The following is a description of a gene set: from publication Zaslavsky E, Hershberg U, Seto J, Pham AM, Marquez S, Duke JL, Wetmur JG, Tenoever BR, Sealfon SC, Kleinstein SH (PMID 20164420) The dendritic cell (DC) is a master regulator of immune responses. Pathogenic viruses subvert normal immune function in DCs through the expression of immune antagonists. Understanding how these antagonists interact with the host immune system requires knowledge of the underlying genetic regulatory network that operates during an uninhibited antiviral response. In order to isolate and identify this network, we studied DCs infected with Newcastle Disease Virus (NDV), which is able to stimulate innate immunity and DC maturation through activation of RIG-I signaling, but lacks the ability to evade the human interferon response. To analyze this experimental model, we developed a new approach integrating genome-wide expression kinetics and time-dependent promoter analysis. We found that the genetic program underlying the antiviral cell state transition during the first 18-hours post-infection could be explained by a single regulatory network. Gene expression changes were driven by a step-wise multi-factor cascading control mechanism, where the specific transcription factors controlling expression changed over time. Within this network, most individual genes are regulated by multiple factors, indicating robustness against virus-encoded immune evasion genes. In addition to effectively recapitulating current biological knowledge, we predicted, and validated experimentally, antiviral roles for several novel transcription factors. More generally, our results show how a genetic program can be temporally controlled through a single regulatory network to achieve the large-scale genetic reprogramming characteristic of cell state transitions. Human Gene Set: GSE18791_UNSTIM_VS_NEWCATSLE_VIRUS_DC_1H_UP species: Homo sapiens Genes up-regulated in comparison of control conventional dendritic cells (cDC) at 1 h versus cDCs infected with Newcastle disease virus (NDV) at 1 h., and this is the list of marker genes: SSTR1, ADAM7, SEMA3F, CRLF1, SDCBP2-AS1, BTBD2, MTURN, TYMSOS, PRL, NPVF, ADPRHL1, SCN4B, SALL3, LIF, SMYD5, BEST2, MAP3K10, JPH1, ABCC12, STPG1, EFNB3, HAGLR, NCAM1, PTPRS (NCBI Gene Id 5802), TMEM38A, PCDH19, DUOXA2, PADI4, ANTXR1, PTTG2, MYL11, B3GALT5-AS1, ACTR3BP2, SERTAD1, TCN1, MAST4, CNTD1, KLK12, KCNJ2-AS1, WNT8B, NPSR1-AS1, TLCD4, LSAMP, PAX7, ATP6V1B1, NUDT9P1, GRK7 (G protein-coupled receptor kinase 7), ENSG00000224090, TIMD4, PTPRF, PARD3, LMX1A, TEX101, FGF12, TAS2R5, ANKRD33, DPP4, SNAP25, ODAD2, LY6D, ASB4, BRS3, LINC00471, CHTF18, STAG3L1, GLRA3, WFDC12, H2BC13, UTS2, TMEM88, PIEZO2, MYLK2, CCNT1, ESRP2, ATP4A, PPY2P, TRIM67-AS1, TEX19 (NCBI Gene Id 400629), KCND3, CCDC120, PTMS, NOXA1, IQCC, PNMA2, TEDDM1, CTSE, CELA1, SLC35D3, TNFRSF8, DYRK1B, CFAP74, ARMC2, GALNT17, ANKS4B, IDO2, RAPGEF4-AS1, TNFRSF19, LINC02223, INO80B, PLA2G2A, CYP3A7, PDX1 (pancreatic and duodenal homeobox 1), ARHGAP42, NKX1-1, TF, CASTOR3P, OR1A2, TTC9B, GAL3ST3, CDH4, HNF1B, NPPA, SMIM6, HOXA11-AS, AKR1B10, ANO7, CYP2C8, SALL4, DMD, LMNTD2-AS1, KIF5A, OFCC1, SLC34A2, CACNG6, ABLIM2 (actin binding LIM protein family member 2), SPEM2, SLC34A3, PIERCE1, ABTB3, SPSB4, TSSK1B, BPIFB6, THBS2, C1orf105, TLE6, LINC02603, WFDC2, SLC25A42, DYNC2I2, NBEAP1, DNAJC9-AS1, ADAMTS7, C6orf52, CCDC181, HID1, BASP1-AS1, GFI1B, SIRPD, GJA10, AR, PARVA, LINC03086, ITM2A (integral membrane protein 2A), PPP2R5B, NXNL1, KLF15, RAB28P5, CCDC7, SLC13A5, SAA3P, PRSS36, ADAM28, GHRHR, ATRNL1, TTR, PALM, PHOX2A, AGT, DMRT2, PLAAT5, PSAPL1, MC2R, ZNF546, SPRR2B, CASP5, DNAAF1, VN1R5, WWC1, LINC00654, PDCL2, ASIC2, SECTM1, KCNA2, LINC00668 (long intergenic non-protein coding RNA 668), TRPV4, UPK3A